Given this list of marker genes Fan1, Cenpx, Fancg, Ubb, Poln, Slx4, Rpa1, Ercc1, Fancc, Mus81, Usp1, Slx1b, Faap100, Faap20, Cenps, Ercc4, Wdr48, Rps27a, Fance, Fancb, here is a description of the gene set: studied in species Mus musculus electronically inferred by orthology from the curated human pathway This event has been computationally inferred from an event that has been demonstrated in another species.<p>The inference is based on the homology mapping from PANTHER. Briefly, reactions for which all involved PhysicalEntities (in input, output and catalyst) have a mapped orthologue/paralogue (for complexes at least 75% of components must have a mapping) are inferred to the other species. Reactome Pathway: Fanconi Anemia Pathway part of: DNA Repair